The following is a description of a gene set: species: Homo sapiens Human Gene Set: GOMF_NEUREGULIN_BINDING Binding to a neuregulin, a member of the EGF family of growth factors., and this is the list of marker genes: ITGA6, ITGB4, ITGB3, ITGAV, ERBB3